The following is a description of a gene set: Genes predicted to be targets of miRBase v22 microRNA hsa-miR-1269a, hsa-miR-1269b in miRDB v6.0 with MirTarget v4 prediction scores > 80 (high confidence targets). studied in species Homo sapiens from publication Chen Y, Wang X (PMID 31504780) Human Gene Set: MIR1269A_MIR1269B, and this is the list of marker genes: SYNDIG1, OSGIN2 (oxidative stress induced growth inhibitor family member 2), DAZ2, PCDHGA8, FOXO1, CCL11, ALG10, KMT2A, MSRA, CREB5 (cAMP responsive element binding protein 5), REST, RER1, ZNF84, ALKBH8, TDRP, RBMS3, PCDHGC3, WAC, MXD3, PCDHGA12, ZFPM2, AGAP1, PCDHGA7, ZNF160, EPHA7, UBFD1, ANKIB1 (NCBI Gene Id 54467), PCDHGA1, PCDHGA5, PCDHGA10, PCDHGB7, RIOX2, BRIP1, TRAF3, DAAM1, PSG5, RHOBTB3, EMX2, USP9X, PPP1R2, ADCY3, SLC25A21, HACD1, PCDHGA9, PCDHGA3, PCDHGA11, URI1, PCDHGA2, PLB1, BPTF, PCDHGB3, GLO1